Given this list of marker genes PER1, CRTC1, RBM4, CREB1, BMAL1, CREM, TFEB, PER2, PER3, RORA, NR1D1, CRY2 (cryptochrome circadian regulator 2), BHLHE40, KMT2A, CIPC, DBP, NPAS2, CLOCK, RORC, SIK1, CREBBP, CRY1, here is a description of the gene set: studied in species Homo sapiens After translocation into the nucleus, the phosphorylated BMAL1:CLOCK heterodimer and, by inference, the BMAL1:NPAS2 heterodimer activate transcription by binding E-box elements (consensus: CANNTG) in the promoters of more than 2000 target genes (inferred from mouse homologs in Hatanaka et al. 2010, Guillaume et al. 2011) and recruiting coactivators such as CREB-binding protein (CREBBP) (inferred from mouse homologs in Garg et al. 2019), the histone methylase KMT2A (MLL1) and, presumably, components of the MLL1 complex (inferred from mouse homologs in Katada and Sassone-Corsi 2010). Transcriptional activation by BMAL1:CLOCK occurs during the day, thus genes regulated by BMAL1:CLOCK are diurnally expressed. <br>Among the thousands of genes activated by BMAL1:CLOCK are the Cryptochrome genes (CRY1, CRY2) and the Period genes (PER1, PER2, PER3) that encode proteins that repress BMAL1:CLOCK activity, forming the primary loop of the circadian clock. BMAL1:CLOCK also activates the expression of Retinoid-related orphan receptor genes RORA, RORB, and RORC and the heme-binding nuclear receptor gene NR1D1 (REV-ERBA) that bind the same ROR responsive elements (RRE, RORE) in the promoters of the BMAL1, CLOCK, and NPAS2 genes. RORA, RORB, RORC activate expression; NR1D1 represses expression. The reciprocal regulation of BMAL1:CLOCK and RORA, RORB, RORC, NR1D1 forms the secondary loop of the circadian clock. Reactome Pathway: Phosphorylated BMAL1:CLOCK (ARNTL:CLOCK) activates expression of core clock genes part of: Circadian clock